Given this list of marker genes ITPA, MFN2 (NCBI Gene Id 9927), BLM, SYT2, GHR, MORC2, CTNND2, FAM111A, PPP1R15B, ADAMTSL2, HSPG2, MED12, ZMPSTE24, NBAS, TRMT10A, CHRNB1, AR, SMARCAL1, GRB10 (NCBI Gene Id 9769), MYH7, RIN2, TRIM37, SEC24D, SELENON, ORC4, RBBP8, MTX2, WRN, NSUN2, IGF1R, SERPINH1, BSCL2, ARID1B, POC1A, LIG4, LMNA, PCNT, SRCAP, TTN, P4HB (prolyl 4-hydroxylase subunit beta), MDM2, SEMA5A, POLD1, FMR1, XRCC4, STAT5B, ERCC4, here is a description of the gene set: A persistent (minutes to hours) abnormal increase in the pitch (frequency) of the voice for the context or social situation or significantly different from baseline of the individual. Human Gene Set: HP_ABNORMALLY_HIGH_PITCHED_VOICE studied in species Homo sapiens Abnormally high-pitched voice